Given this list of marker genes POLR2K, TAF6L, TAF11L12, TAF7L, MYZAP, POLR2F, TAF12, GTF2H2C, POLR2L, TAF1, GTF2H2C_2, TAF11L4, TAF11L14 (NCBI Gene Id 112488740), TAF11L11, RTF1, TAF11L8, TAF13, TAF9, POLR2D, TAF11, CDC73, ERCC3, CCNH, GTF2A2, SUPT3H, TAF11L13, TAF7, TAF11L3, POLR2C, TAF11L10, GTF2H3, GTF2E2, TADA3, GTF2F2, POLR2J3, TAF5, TAF4B, TAF11L6, PAAF1, ERCC2, GTF2A1L (general transcription factor IIA subunit 1 like), TAF4, POLR2I, POLR2J, TAF5L, CDK7, TUFT1, SKIC8, TAF9B, GTF2H4, POLR2M, TBPL1, TAF10, KAT2A, POLR2H (NCBI Gene Id 5437), MNAT1, GTF2H1, USP22, PAF1, GTF2B, TAF1L, TAF8, GTF2H5, CTR9, ATXN7, ATXN7L3, TRRAP, POLR2G, POLR2A, POLR2E, TAF11L9, GTF2A1, LEO1, TAF6, GTF2E1, TBP, ENY2, TAF11L7, PEX2, GTF2H2, POLR2J2, MMS19, POLR2B, TAF3, TAF2, TCEA1, TAF11L2, GTF2F1, here is a description of the gene set: studied in species Homo sapiens A nuclear DNA-directed RNA polymerase complex containing an RNA polymerase II core enzyme as well as additional proteins and transcription factor complexes, that are capable of promoter recognition and transcription initiation from an RNA polymerase II promoter in vivo. These additional components may include general transcription factor complexes TFIIA, TFIID, TFIIE, TFIIF, or TFIIH, as well as Mediator, SWI/SNF, GCN5, or SRBs and confer the ability to recognize promoters. Human Gene Set: GOCC_RNA_POLYMERASE_II_HOLOENZYME